Given this list of marker genes H4c17, Xpo1, Pdpk1, Polr2f, Gnb2, Strn, Kdm1a, H2bc7, H4c12, Shc1, Pik3r2 (NCBI Gene Id 18709), Polr2k, Tgfa, Foxa1, Gtf2f2, Carm1, Gngt2, H4c9, Gng7, Gtf2f1, Egfr, H3c2, Ep300, H4c8, Ppp5c, H3c10, Mmp2, H3c13, Gnb5 (guanine nucleotide binding protein (G protein), beta 5), Gngt1, Zdhhc21, H3c7, Btc, Tbp, H2bc11, Polr2a, H4c2, H4c6, Polr2c, H3c15, H2ac1, Usf2, H2bc1, Cbfb, Gnb3, Ptk2, H4c4, H2bc13, Erbb4, H3c11, Areg (NCBI Gene Id 11839), H2bc9, Gng11, Hras, H4c1, H3c1, H2bc27, Esr1, Gnat3, H2bc15, H4c3, Kat5, Gng3, Zdhhc7, Polr2i (polymerase (RNA) II (DNA directed) polypeptide I), Cav2, Gata3, Fkbp4, Polr2l, H3c3, Calm1, H4c18, H2bc22, Ncoa1, H2bc3, H4c11, Gng5, H3c4, Gng4 (NCBI Gene Id 14706), Gtf2a1, Mapk3, Hspb1 (NCBI Gene Id 15507), H4c14, Epgn, H3f3a, Cav1, Esr2, Cdkn1b, H3c8, Gnai1, H2bc8, Ppid, Mmp3, Polr2e (NCBI Gene Id 66420), Polr2b, S1pr3, H2bc12, Gng8, Med1, H3c6, Gng10, Mmp7, Cited1, here is a description of the gene set: Reactome Pathway: ESR-mediated signaling This event has been computationally inferred from an event that has been demonstrated in another species.<p>The inference is based on the homology mapping from PANTHER. Briefly, reactions for which all involved PhysicalEntities (in input, output and catalyst) have a mapped orthologue/paralogue (for complexes at least 75% of components must have a mapping) are inferred to the other species. studied in species Mus musculus electronically inferred by orthology from the curated human pathway part of: Signaling by Nuclear Receptors